The following is a description of a gene set: This event has been computationally inferred from an event that has been demonstrated in another species.<p>The inference is based on the homology mapping from PANTHER. Briefly, reactions for which all involved PhysicalEntities (in input, output and catalyst) have a mapped orthologue/paralogue (for complexes at least 75% of components must have a mapping) are inferred to the other species. studied in species Mus musculus electronically inferred by orthology from the curated human pathway Reactome Pathway: Interconversion of 2-oxoglutarate and 2-hydroxyglutarate part of: Aerobic respiration and respiratory electron transport, and this is the list of marker genes: L2hgdh, D2hgdh